Given this list of marker genes MYOD1, SAP18, FOXO1, VDR, IGHA1, HDAC2, ATF3, IL5, SMAD7, KAT2B, MYC, IL10 (NCBI Gene Id 3586), NCOA2, NR3C1, FOXH1, SIN3A, CREB1, CDKN2B, SKIL, NCOA1, TGIF2, AR, RBBP7, IRF7, DLX1, CDK4, FOXG1, ATF2, RUNX1, AKT1, LAMC1, HSPA8, ESR1, HNF4A, CEBPB, SMAD2, FOXO3, CREBBP, HDAC1, SAP30, NKX2-5, CDK2, CITED1, PIAS4, SNIP1, JUN, E2F4, MAX, RBL1, RUNX2, TCF3, ZBTB17, EP300, SKI, PIAS3, TGIF1, SERPINE1, DCP1A, KAT2A, SIN3B, TFDP1, CDKN1A, MED15, GSC, GATA3, IFNB1, SP3, CBFB, RUNX3, NCOR1, SP1, SMAD4, RBBP4, CTBP1, TFE3, COL1A2, FOXO4, MEF2C, ITGB5, SMAD3, E2F5, FOS, here is a description of the gene set: from publication Schaefer CF, Anthony K, Krupa S, Buchoff J, Day M, Hannay T, Buetow KH (PMID 18832364) Human Gene Set: PID_SMAD2_3NUCLEAR_PATHWAY Regulation of nuclear SMAD2/3 signaling species: Homo sapiens